Given this list of marker genes Hook1, Castor2, Pias1, Ubl3 (ubiquitin-like 3), Flrt3, Abcc1, Cadm1, Cd80, Plk2 (polo like kinase 2), Naa80 (N(alpha)-acetyltransferase 80, NatH catalytic subunit), Tmem43, Fam83g, Mpzl2, Ctnnd1, Ccny, Atp2c1, Gjb6, Ccdc65, 6430548M08Rik, Tmem106b, Slc6a20a (solute carrier family 6 (neurotransmitter transporter), member 20A), Oga, Lyg1, Schip1, Snx9, Rfng, Peak1, Rapgef3, Arid3a, Hmox1, Ahcyl2 (S-adenosylhomocysteine hydrolase-like 2), Fmn1, Atp13a3, Defb1, Hapstr1, Akr1d1, Cat, Abcg1, Prcc, Slpi, Fcna (NCBI Gene Id 14133), Spred3, Qki, Or2b2, Macf1, Git2, Fhod1, Arnt, Nrip1, Commd10, Galnt12, Pik3cb, Klk12, Pld1, Sema6d, Ccng1, Gba1, Kif5b, Tmem47, Pde6b, Pxk, Mxd1, Utrn, Blcap, Aff4, Fetub, Btbd10, Crybg3, Krt13, Aqp3, Lama3, Nrg1, Net1 (NCBI Gene Id 78563), Stx11, Clip1, Hba-a2, Dhx37, Crabp2, Gsta4, Ubl4a, Zfp131, Tpm4, Shroom3, Kif1b, Fabp4, Nfe2l2, Tpp1, Acox1, Ubap1, Nploc4, Stk3, Tbl1x, Tpm1, Wdfy2, Tpd52, Flrt2, Tpbg, Myh9, Aplp2, Rbm25, Itgb1, Maged2, Kdm5b, Mapk6, Fam168b, Atf7ip, Fchsd2, Rbbp4, Myh6, Esd (esterase D/formylglutathione hydrolase), Lrrc57, Adam12 (ADAM metallopeptidase domain 12), Ddx3x, Snn, Ly6k, Ank3, Pip5k1b, Dsg3, Dip2b, Dedd, Hmgcs1, Hpgds, Cdc40, Asap1, Smg1, Ralb, Med13, Ptpn12, Plpp6, Pmepa1, Tatdn2, Pdpn, Ltn1, Agps, Pnck, Smad7, Larp4b, Ubash3b, Itga6, Ddx6, Hmmr, Arap2 (ArfGAP with RhoGAP domain, ankyrin repeat and PH domain 2), Adnp, Cmtm4, Stim2, Dlg1, Ddx49, Il36g, Eps8, Gsr, Ranbp9, Cast, Mboat1, Slc4a7, Cpne2, Klf3, Mafk, Chi3l1, Entr1, Ptgs2, Enah, Ripk1, Klk10, Esm1, Or2b2b, Pmaip1, Gpat3, Lin9, Clip4, Dpp8, Apln, Tmem248, Tmx3, Tmem163, Irs2, Hs3st1 (NCBI Gene Id 28009), Nvl, Met, Gsta1, Ccdc88a, Csrnp1, Runx1, Sqle, Camk2d, Klf6, Vgll3, Bcar3, Ptbp3, Hipk3 (NCBI Gene Id 15259), Eea1, Fos, Zdhhc5, Ell2, Cobll1 (Cobl-like 1), Farsb, Rap1gap, Map3k20, Kcnn4 (NCBI Gene Id 16534), Rab11fip1, Zfp46, Pfn1, Zhx2, Phlda1, Gkn1 (NCBI Gene Id 66283), Taok1, Nsdhl, Camsap2 (NCBI Gene Id 75184), Dock1, Lxn, Rnf38 (NCBI Gene Id 73469), Ube2q2 (NCBI Gene Id 76838), Aldh1a3, Mau2, Hba-a1, Rbp1, Tiparp, Lgals3bp, Sema3c, Ripk4, Cep350, Cpeb4, Rab22a, B4galt1 (NCBI Gene Id 99960), Prpf4b, Tgfbi, Rusc2, N4bp1, Fblim1, Myo5b, Serpinb6a, Pak1, Homer3, Gm2a, Ptprz1, Hoxa1 (homeobox A1), Ywhaz, Eaf1, Crebbp, Sema4d, Phldb2, Map4k4, Cd44, Tnpo1, Defb4, Dapk2, Gsk3b, Mmp10, Letmd1, Degs2 (NCBI Gene Id 70059), Adarb1, Gpr137b, Hdac6, Add2, Twf1, Ly6m, Uck2, Defb14, Xdh, Odc1, Lrp8, Yod1, Samhd1, Smurf1, Ugcg, Mmp3, Nptx1, Usf3, Dcun1d3, Dap, here is a description of the gene set: from publication Durchdewald M, Guinea-Viniegra J, Haag D, Riehl A, Lichter P, Hahn M, Wagner EF, Angel P, Hess J (PMID 18757399) Genes down-regulated upon skin specific knockout of FOS by cre-lox in the K5-SOS-F mice (express a constitutively active form of SOS1 in the skin). Expression and function of the oncogenic transcription factor activator protein (AP-1; mainly composed of Jun and Fos proteins) is required for neoplastic transformation of keratinocytes in vitro and tumor promotion as well as malignant progression in vivo. Here, we describe the identification of 372 differentially expressed genes comparing skin tumor samples of K5-SOS-F transgenic mice (Fos(f/f) SOS(+)) with samples derived from animals with a specific deletion of c-Fos in keratinocytes (Fos(Deltaep) SOS(+)). Fos-dependent transcription of selected genes was confirmed by quantitative real-time PCR analysis using tumor samples and mouse back skin treated with the tumor promoter 12-O-tetradecanoylphorbol-13-acetate (TPA). One of the most differentially expressed genes encodes the small mucin-like glycoprotein Podoplanin (Pdpn), whose expression correlates with malignant progression in mouse tumor model systems and human cancer. We found Pdpn and Fos expression in chemically induced mouse skin tumors, and detailed analysis of the Pdpn gene promoter revealed impaired activity in Fos-deficient mouse embryonic fibroblasts, which could be restored by ectopic Fos expression. Direct Fos protein binding to the Pdpn promoter was shown by chromatin immunoprecipitation and a TPA-induced complex at a TPA-responsive element-like motif in the proximal promoter was identified by electrophoretic mobility shift assays. In summary, we could define a Fos-dependent genetic program in a well-established model of skin tumors. Systematic analysis of these novel target genes will guide us in elucidating the molecular mechanisms of AP-1-regulated pathways that are critically implicated in neoplastic transformation and/or malignant progression. Mouse Gene Set: DURCHDEWALD_SKIN_CARCINOGENESIS_DN species: Mus musculus